Given this list of marker genes ABCG5, ABCG8, ABCC9, ATP13A1, ABCB10, ABCD3, ABCC8, ABCD2, ABCB1, ABCC11, CFTR, ABCA9, ABCC12 (NCBI Gene Id 94160), TAP1, ABCB9, SLC36A1, ABCA3, ATP13A3, ABCB4, TAP2, ABCA12, ABCC3, ABCC10, ABCA4, ABCA2, RALBP1, ABCD4, ABCA8, ABCA1, ABCC5, ABCB11 (NCBI Gene Id 8647), ABCB7, ABCG4 (NCBI Gene Id 64137), ABCD1, ABCB6, ABCB8, ATP13A2, ABCA5, ABCC2 (ATP binding cassette subfamily C member 2), ABCB5, ABCA13, ABCA10, ABCG2, ABCC6, ABCC1, ABCA7 (NCBI Gene Id 82843), ABCA6, ABCG1, ABCC4, here is a description of the gene set: studied in species Homo sapiens Human Gene Set: GOMF_ABC_TYPE_TRANSPORTER_ACTIVITY Primary active transporter characterized by two nucleotide-binding domains and two transmembrane domains. Uses the energy generated from ATP hydrolysis to drive the transport of a substance across a membrane.